Given this list of marker genes Gpnmb, Dsc3, Lyl1, Rnf207, Tekt2, Gucy1a1, Gpat2, Apbb1ip, Loxl3, Igf1, Mchr1, Rflna, Fxyd5, Hoxb13, Dkk1, Nr5a1, Papln, Cdkn2c, Pth2r, Pde8b, Etv2, Psmb11, Pamr1, Ccer1, Sez6l2, Ucp1, Cox4i2, Wnt8a, Hspa12b, Slfn5, Tmem181b-ps, Sptssb, Aqp2, Kcnd2 (NCBI Gene Id 97339), AI593442, Tnfrsf8, Klhl1, Ido1, Grm3, Nol4, Pvalb, Ptgfr (NCBI Gene Id 99762), Epn3, Tcam1 (testicular cell adhesion molecule 1), Rhoj, Col4a4, Adarb2, Ptn, Pdyn, Chodl, Coro1a, Evpl, Npy2r, Zfp608, Fibin, Prss36, Rgs8, Cdhr4, Mst1r, Nrbp2, Vrtn, Ncan, Prokr1, Mogat1, Meltf, Col4a3, Cacng3, Crabp2 (cellular retinoic acid binding protein II), Spink2, Extl1, Pde11a, Phyhip, Clec14a, Ggt7, Tnfrsf13c, Pcdh20, Chst3, Fgl2, Best2, Marchf1, Lta, Pde1c, Rem2, Tmem45b, Sgcd, Lefty1, Gas2l2, Osm, Npy1r, Kcnj2, Esrp1, Cd44, Tmem26, Gnat1, Lama4, Cntnap1, Brinp3, Ptgs1, Myl7, Kcnj5, Kcnn3, Adamts16, Ccdc38, Opcml, Edn2, Zfp354b (NCBI Gene Id 27274), Tbata, Scnn1a, Gpr84, Col1a2, H2-T3, Nol3, Aqp6, Ciita, Tgfb3, Mfsd2b, Slitrk1, Pcare, Adam33, Tlr5, Cnmd, Rapgef3, Pax5, Tssk3, Susd4, Myzap, Tspan11, Islr, Fgf10, Abcc3, Alox8, Tlr12, Avpr1b, Islr2, Piwil2, Tfpi2, Sult2b1, Pak5, here is a description of the gene set: We report the application of single-molecule-based sequencing technology for high-throughput profiling of histone modifications in mammalian cells. By obtaining over four billion bases of sequence from chromatin immunoprecipitated DNA, we generated genome-wide chromatin-state maps of mouse embryonic stem cells, neural progenitor cells and embryonic fibroblasts. We find that lysine 4 and lysine 27 trimethylation effectively discriminates genes that are expressed, poised for expression, or stably repressed, and therefore reflect cell state and lineage potential. Lysine 36 trimethylation marks primary coding and non-coding transcripts, facilitating gene annotation. Trimethylation of lysine 9 and lysine 20 is detected at satellite, telomeric and active long-terminal repeats, and can spread into proximal unique sequences. Lysine 4 and lysine 9 trimethylation marks imprinting control regions. Finally, we show that chromatin state can be read in an allele-specific manner by using single nucleotide polymorphisms. This study provides a framework for the application of comprehensive chromatin profiling towards characterization of diverse mammalian cell populations. Mouse Gene Set: MIKKELSEN_ES_ICP_WITH_H3K4ME3_AND_H3K27ME3 Genes with intermediate-CpG-density promoters (ICP) bearing bivalent histone H3 methylation mark (H3K4me3 and H3K27me3) in embryonic stem cells (ES). species: Mus musculus from publication Mikkelsen TS, Ku M, Jaffe DB, Issac B, Lieberman E, Giannoukos G, Alvarez P, Brockman W, Kim TK, Koche RP, Lee W, Mendenhall E, O'Donovan A, Presser A, Russ C, Xie X, Meissner A, Wernig M, Jaenisch R, Nusbaum C, Lander ES, Bernstein BE (PMID 17603471)